The following is a description of a gene set: studied in species Homo sapiens Genes up-regulated in rectal but down-regulated in colon carcinoma compared to normal mucosa samples. Human Gene Set: GRADE_COLON_VS_RECTAL_CANCER_UP To characterize patterns of global transcriptional deregulation in primary colon carcinomas, we did gene expression profiling of 73 tumors using oligonucleotide microarrays. For 30 of the tumors, expression profiles were compared with those from matched normal mucosa samples. We identified a set of genes with highly significant deregulation between tumors and mucosa samples (P < 1e-7). A significant proportion of these genes mapped to chromosome 20 (P = 0.01). Seventeen genes had a >5-fold average expression difference between normal colon mucosa and carcinomas, including up-regulation of MYC and of HMGA1, a putative oncogene. Furthermore, we identified genes that were significantly differentially expressed between lymph node-negative and lymph node-positive tumors (P < 0.001), the functional annotation of which revealed a preponderance of genes that play a role in cellular immune response and surveillance. The microarray-derived gene expression levels of 20 deregulated genes were validated using quantitative real-time reverse transcription-PCR in >40 tumor and normal mucosa samples with good concordance between the techniques. Finally, we established a relationship between specific genomic imbalances, which were mapped for 32 of the analyzed colon tumors by comparative genomic hybridization, and alterations of global transcriptional activity. Previously, we had conducted a similar analysis of primary rectal carcinomas. The systematic comparison of colon and rectal carcinomas revealed a significant overlap of genomic imbalances and transcriptional deregulation, including activation of the Wnt/beta-catenin signaling cascade, suggesting similar pathogenic pathways. from publication Grade M, Hörmann P, Becker S, Hummon AB, Wangsa D, Varma S, Simon R, Liersch T, Becker H, Difilippantonio MJ, Ghadimi BM, Ried T (PMID 17210682), and this is the list of marker genes: STX2, GADD45B, FOCAD, PMP2, ADGRF5, ENGASE, DDX50, CEMIP, CD34, FAM217B, ENOX2, JUNB, ASF1B, UMPS, FSTL1, RNASEH2B, HNRNPC, EMCN, DESI2, CANX, RHOQ, PALMD (palmdelphin), BCL11B, CTPS1, INSIG2, RAD18, LAGE3, ERO1A, TEX10, ZWILCH, HABP4, IL1A, HTRA3 (HtrA serine peptidase 3), PCDH20, RPRD1A, MAP3K20, RYK, ALG5